Given this list of marker genes RFC3 (replication factor C subunit 3), STK11, DNA2, DAXX, TP53, RAD50, BRD1, GATAD2B, PIP4K2B (NCBI Gene Id 8396), HDAC1, CCNG1, CDK2, RHNO1, CDK5, PHF20, TAF9B, PIP4K2A, MBD3, RPA3, RPS27A, CDK1, TBP (TATA-box binding protein), EXO1, HIPK1, PRKAB2, CHEK1 (checkpoint kinase 1), NBN, MAPKAP1, MRE11, CDKN2A, RFC4, RPA1, RBBP4, TAF9 (TATA-box binding protein associated factor 9), PRKAA2, TOP3A, TAF3, ATR, SGK1, PLK3 (NCBI Gene Id 1263), AKT3, BRD7, UBC, MAPK14, TAF5, BANP, HUS1, TAF10, CSNK2A1, ING5, KMT5A, TAF7L, MTOR, NOC2L, MTA2, BRPF1, TAF13, L3MBTL1, RAD17, TAF2, ATM, SUPT16H, CSNK2A2, TP63 (NCBI Gene Id 8860), BRPF3, TTC5, SETD9, JMY, TAF1, PDPK1, PIP4P1, TOPBP1, TAF11, KAT6A, UBB, USP2, RFFL, PML, PPP1R13L, PPP2R5C, RFC5, CDK5R1, MDM4, PRKAB1, POU4F2, PRKAG2, EHMT1, RFC2, SSRP1, PRKAA1, NUAK1, PPP2R1B, UBA52, SMYD2, HIPK2, WRN, RAD9B, CHEK2, RNF34, TAF4B, USP7, GATAD2A, PPP2CA, RBBP8, POU4F1, PRR5, RBBP7, MEAF6, RAD9A, TP53RK, ING2, BRCA1, EP300, AKT2, KAT5, RMI2, TAF15, MAPK11, MLST8, PPP2R1A, HDAC2, PIN1, CCNA1, TAF12, CCNA2, PPP2CB (NCBI Gene Id 5516), TAF7, CHD4, PRDM1, TP73, CSNK2B, BLM, TAF1L, BARD1, CHD3, PPP1R13B, PIP4K2C, AURKA, RAD1, TP53INP1, MDM2, MAP2K6, AKT1, TP53BP2, PRKAG1, RPA2, AURKB, RICTOR, MAPKAPK5, ATRIP, ZNF385A, DYRK2, TAF4, TAF6, RMI1, BRIP1, PRKAG3, PRMT5, TPX2, EHMT2, here is a description of the gene set: species: Homo sapiens Regulation of TP53 Activity Human Gene Set: REACTOME_REGULATION_OF_TP53_ACTIVITY